The following is a description of a gene set: Human Gene Set: GSE41176_UNSTIM_VS_ANTI_IGM_STIM_BCELL_6H_DN species: Homo sapiens from publication Shinohara H, Behar M, Inoue K, Hiroshima M, Yasuda T, Nagashima T, Kimura S, Sanjo H, Maeda S, Yumoto N, Ki S, Akira S, Sako Y, Hoffmann A, Kurosaki T, Okada-Hatakeyama M (PMID 24833394) Genes down-regulated in B lymphocytes: untreated versus anti-IgM for 6h. The activation signaling of transcription factor nuclear factor-kB (NF-kB) plays central role for immune system. One of key kinase mediating this pathway is TAK1 in adaptive and innate immunity. However, role of TAK1 in B cell receptor signaling is still unclear. To know effects of TAK1-deletion on the gene expression induced by anti-IgM, we performed the time course analysis in comparison of wild type with TAK1-deleted splenic B cells., and this is the list of marker genes: CSF1, HARS2, PIK3AP1, SSBP2, ADORA2A, RNF31, AMER3, PLPP6, CCNC, PRXL2A, ENTPD5, NMRK1 (nicotinamide riboside kinase 1), MYD88, YOD1, STAC, FN1, GCH1, PIAS2, HHEX, CHD7, SCN9A, ATXN7, ST3GAL5, CRYGN, TRPS1 (transcriptional repressor GATA binding 1), CENPT (centromere protein T), CASK, RB1CC1, DCUN1D3, C1GALT1, SCARF1, CD40LG, CASP1, BHLHE40, BLCAP, ADAM10, TNFSF10, IL15RA, ZFP36L2, MID1IP1, CDADC1, SIAH2, GRIPAP1, CTSW, ATP8A1, IFITM3, TEK, BFAR, ATG4B, BTBD6, RUNX3, ADA, DTL, PTPN3, KLF12, CREBBP, ST8SIA1 (ST8 alpha-N-acetyl-neuraminide alpha-2,8-sialyltransferase 1), DGKI, CHSY1, PATL1, BCL2L2, PAQR4, MAGEH1, SERPINB9, HMOX1, RASSF5, TTC19, NEDD9, FNBP4, CHCHD10, HDAC4, ACAA2, CUL2, IFITM2, RNF168, DTX2, SCIN, CXCL11, WDR53, IL17RA, AGFG1, ACADL, RABGAP1, EMP3, ARL2BP, NKAPD1, E2F3, IL13, RDH10, NTS, HNRNPH3, TAPT1, FGF13, GGPS1, SSTR3, RAB12 (RAB12, member RAS oncogene family), BRAF, RUNX2, PTPN13, SLC30A9, MAPK11, H3C7, GLS2, TNFSF14, POLR1C (RNA polymerase I and III subunit C), DQX1, ZMYM2, RREB1, PCMT1, DLGAP4, DUSP11, SMC6, STAM, RSBN1, PURG, PPM1B, CSF2, ATG16L1, SLA, LRIG2, FNDC8 (NCBI Gene Id 54752), ISG20, MBD6, PTAFR, PRR5, RBM4B, PCNX1, SEMA7A, UBR3, NEMF, CPS1, PTK6, CPEB4, TEF, CHMP5, PPM1J (NCBI Gene Id 333926), CDKN2AIP, TCHH, HERC1, INTS6L, SLC30A7, TRAF3IP2, CPNE3, PHRF1, NCSTN, DUSP16, ARHGAP25 (NCBI Gene Id 9938), IKZF5, RTP4, SHANK3, LRRC73, IFNG, AP2A2, PPWD1, ZNF329, ALPK2, CLEC7A, MYO6, CAMK2N1, FASLG, FBXO46, ITPRIP, SNORD104, ZC3HAV1, CRABP2, GPM6B, ATXN3 (ataxin 3), HMGN5, THRAP3, BTBD19, B4GALT3, TGM4, ZXDB, JADE2, FBXL3, AXIN2, GSAP, RAB43, KIF13B, PTTG1IP, ZUP1, RNF103, SNHG6, MAD2L1BP, LENG1, CCR7, SLC66A1, CDC6, FMR1, TIMP1, ATP6AP2, C1QTNF12, SLC25A14, SIX6, DBP, SLC25A44, MINDY2, LLGL2, HRH4, PDLIM1